Given this list of marker genes ATM, ATR, NSD2, PAXIP1, POLE2, APBB1, CDK2, BAZ1B, RFC1, EME1, H2BC14, SEM1, MRE11, KDM4A, H2BC3, H2BC21, DNA2, UBE2V2, RFC5, NBN, XRCC2, POLL, H2BC26, CCNA2, TOPBP1, PPP4C, EYA1, H2BC5, NHEJ1, RAD9A, TP53, ABRAXAS1, POLD3, RAD51D, H2BC11, XRCC4, TDP1, BLM, POLD4, UBB, EYA4, XRCC3, HERC2, H2BC9, MDC1, H4C1, POLH, XRCC5 (X-ray repair cross complementing 5), RNF168, H2BC12, PARP2, H2BC15 (H2B clustered histone 15), CHEK1, RPS27A, FIGNL1, H2BC13, POLQ, DCLRE1C, RAD51, RNF8, RFC3, RAD51AP1, POLE4, H3-4, UBXN1, PARP1, H2BC1, UIMC1, EXO1, KDM4B, UBE2I, SIRT6, GEN1, PIAS4, PPP5C, SMARCA5, POLE3, SUMO1, UBE2N, H2BC17, RFC4, RPA3, RMI1, POLM, RTEL1, RHNO1, MUS81, FIRRM, BABAM1, FEN1, PCNA, KAT5, POLE, BARD1, POLD1, TOP3A, CHEK2, H2BC4, RAD9B, TIPIN (TIMELESS interacting protein), BAP1, PALB2, EYA3, H2BC12L, RAD17, RMI2, RPA2, RAD1, XRCC1, RNF4, TDP2, RIF1, EME2, TIMELESS, PPP4R2 (NCBI Gene Id 56340), RAD51C, PRKDC, POLD2, ABL1, EYA2, TP53BP1, RBBP8, SLX1A, LIG1, BABAM2 (NCBI Gene Id 9577), CLSPN, UBC, SLX4, SUMO2, WRN, CCNA1, HUS1, BRCA1, BRCC3, ERCC1, BRCA2, LIG3, ATRIP (ATR interacting protein), RPA1, RAD52, UBA52, LIG4, MAPK8, POLK, KPNA2, XRCC6 (X-ray repair cross complementing 6), RAD51B, ERCC4, RAD50, SPIDR, H2AX, BRIP1, RFC2, here is a description of the gene set: part of: DNA Repair Double-strand breaks (DSBs), one of the most deleterious types of DNA damage along with interstrand crosslinks, are caused by ionizing radiation or certain chemicals such as bleomycin. DSBs also occur physiologically, during the processes of DNA replication, meiotic exchange, and V(D)J recombination.<p>DSBs are sensed (detected) by the MRN complex. Binding of the MRN complex to the DSBs usually triggers ATM kinase activation, thus initiating the DNA double strand break response. ATM phosphorylates a number of proteins involved in DNA damage checkpoint signaling, as well as proteins directly involved in the repair of DNA DSBs. DSBs are repaired via homology directed repair (HDR) or via nonhomologous end-joining (NHEJ).<p>HDR requires resection of DNA DSB ends. Resection creates 3'-ssDNA overhangs which then anneal with a homologous DNA sequence. This homologous sequence can then be used as a template for DNA repair synthesis that bridges the DSB. HDR preferably occurs through the error-free homologous recombination repair (HRR), but can also occur through the error-prone single strand annealing (SSA), or the least accurate microhomology-mediated end joining (MMEJ). MMEJ takes place when DSB response cannot be initiated.<p>While HRR is limited to actively dividing cells with replicated DNA, error-prone NHEJ pathway functions at all stages of the cell cycle, playing the predominant role in both the G1 phase and in S-phase regions of DNA that have not yet replicated. During NHEJ, the Ku70:Ku80 heterodimer (also known as the Ku complex or XRCC5:XRCC6) binds DNA DSB ends, competing away the MRN complex and preventing MRN-mediated resection of DNA DSB ends. The catalytic subunit of the DNA-dependent protein kinase (DNA-PKcs, PRKDC) is then recruited to DNA-bound Ku to form the DNA-PK holoenzyme. Two DNA-PK complexes, one at each side of the break, bring DNA DSB ends together, joining them in a synaptic complex. DNA-PK complex recruits DCLRE1C (ARTEMIS) to DNA DSB ends, leading to trimming of 3'- and 5'-overhangs at the break site, followed by ligation. <p>For review of this topic, please refer to Ciccia and Elledge 2010. studied in species Homo sapiens Reactome Pathway: DNA Double-Strand Break Repair